The following is a description of a gene set: Genes positively differentially expressed in cell type: γδ T cell upon treatment with cytokine: TL1A in mouse lymph nodes in vivo. Mouse Gene Set: CUI_T_CELL_GD_TL1A_RESPONSE_UP species: Mus musculus from publication Cui A, Huang T, Li S, Ma A, Pérez JL, Sander C, Keskin DB, Wu CJ, Fraenkel E, Hacohen N (PMID 38057668) Cytokines mediate cell-cell communication in the immune system and represent important therapeutic targets. A myriad of studies have highlighted their central role in immune function, yet we lack a global view of the cellular responses of each immune cell type to each cytokine. To address this gap, the authors created the Immune Dictionary, a compendium of single-cell transcriptomic profiles of more than 17 immune cell types in response to each of 86 cytokines (>1,400 cytokine-cell type combinations) in mouse lymph nodes in vivo. A cytokine-centric view of the dictionary revealed that most cytokines induce highly cell-type-specific responses. For example, the inflammatory cytokine interleukin-1β induces distinct gene programmes in almost every cell type. A cell-type-centric view of the dictionary identified more than 66 cytokine-driven cellular polarization states across immune cell types, including previously uncharacterized states such as an interleukin-18-induced polyfunctional natural killer cell state., and this is the list of marker genes: Ccdc124, Ncoa7, H2-Q7, Usp5, Cd74, Tmem154, Edf1, Serpina3g, Adam8, Tfe3, Ptp4a2, Tcea1, Gadd45b, Nfkbib, Creld2, Tmem147, Gdpd5, Nop16, Ppa1, Birc3, Mettl1, Pon2, Zeb2, Jade2, Manf, Cxcl10, H2-K1, H2-D1, Cdc37, Tnip1, Zmiz2 (zinc finger, MIZ-type containing 2), Tubb4b, Fbl, Tbl1xr1 (NCBI Gene Id 99912), Uqcrq, Ankrd12, Ly6a, Lars1 (NCBI Gene Id 73060), Ssr2, Atp5mc1, Marcksl1 (NCBI Gene Id 17357), Ly6g5b, Septin11, Batf, Trp53, B2m, Nedd4, Lpcat1, Mapkapk2, Psma7, Elp5, Ddx39a, Relb, Stx11, Banf1, Tapbp, Csnk2a1, Ly6e, Yaf2, Chd4, Ikbke, Nme1, Vars1, Hnrnpa3, Set, Pcbp1, Ier5, Shmt2, Tnfrsf9, Kmt2a, M6pr, Psme1, Ehd1, Jak2, Sms, Prr29 (proline rich 29), Psmb5, Eif4a1, Nfkbia, Tmem176b, Hyou1, Mpc1, Tcp1, Grap (NCBI Gene Id 71520), Odc1, Fzr1, Psma2, Med11, Pfn1, Sar1a (NCBI Gene Id 67913), Cd83, Apobec3, Ptma, Nfkb1, Ppp1r14b, Pim2, Tmsb10, Degs1, Ola1, Stat1, Ran, Tapbpl, Hsp90ab1, Canx, Stt3b, Parp14, Hspa5, Psmb10 (NCBI Gene Id 19171), Sdhaf1, Icam1, Dennd5a, G3bp1, Sumo2, Mvp, Lcp1, Eif2s2, Pa2g4, Dkc1, Traf1, Fam107b, Furin, Kdm2b, Ahcyl2, Cyba, Gbp4, Senp6, Foxp4, Pdia6, Apex1, Nop58, Npm1, Cops6, Sting1, Rnf19b, Ncl, Nfkb2, Mars1, Pdia3, Sdc4, Pou2f2, Ltb, Cd82, Cd44, Bcl3, Sdf2l1, Stat6, Aebp2, Ctdnep1, Psme2, Herpud1, Hmgn3, Nhp2, Creb1, Ep400, Tyk2, Bcl2a1b, Tgfb1, Ptpn7, Tspan3, Nfkbie, Tuba1b, Abcc1, Mrpl14, Ppia, Hsp90b1, Lta, H2-Q6, Sec11c, Ranbp1, Irf5, Eif5a, Pdcd1lg2, Calr